Given this list of marker genes MT1X, COG6, HSD17B4, IL17RB, GORAB, PMEPA1, PTEN, KDSR, GOLPH3, PWWP2A, SHC3, H2AC6, TAF10, ZNF260, RGCC, BHLHE40, CLSPN, TIMD4, WWC1, here is a description of the gene set: from publication Kyng KJ, May A, Kølvraa S, Bohr VA (PMID 14527998) Werner syndrome (WS) is a premature aging disorder, displaying defects in DNA replication, recombination, repair, and transcription. It has been hypothesized that several WS phenotypes are secondary consequences of aberrant gene expression and that a transcription defect may be crucial to the development of the syndrome. We used cDNA microarrays to characterize the expression of genes and ESTs across a panel of 15 primary human fibroblast cell lines derived from young donors, old donors, and WS patients. Of the analyzed genes, 6.3% displayed significant differences in expression when either WS or old donor cells were compared with young donor cells. This result demonstrates that the WS transcription defect is specific to certain genes. Transcription alterations in WS were strikingly similar to those in normal aging: 91% of annotated genes displayed similar expression changes in WS and in normal aging, 3% were unique to WS, and 6% were unique to normal aging. We propose that a defect in the transcription of the genes as identified in this study could produce many of the complex clinical features of WS. The remarkable similarity between WS and normal aging suggests that WS causes the acceleration of a normal aging mechanism. This finding supports the use of WS as an aging model and implies that the transcription alterations common to WS and normal aging represent general events in the aging process. Human Gene Set: KYNG_WERNER_SYNDROM_DN studied in species Homo sapiens Genes distinctly down-regulated in primary fibroblast cultures from Werner syndrom patients compared to those from normal young donors.